The following is a description of a gene set: from publication Nakamura T, Fidler IJ, Coombes KR (PMID 17210693) To determine the influence of the microenvironment on changes in gene expression, we did microarray analysis on three variant lines of a human pancreatic cancer (FG, L3.3, and L3.6pl) with different metastatic potentials. The variant lines were grown in tissue culture in the subcutis (ectopic) or pancreas (orthotopic) of nude mice. Compared with tissue culture, the number of genes of which the expression was affected by the microenvironment was up-regulated in tumors growing in the subcutis and pancreas. In addition, highly metastatic L3.6pl cells growing in the pancreas expressed significantly higher levels of genes than did the L3.3 or FG variant cells. Growth of the variant lines in the subcutis did not yield similar results, indicating that the orthotopic microenvironment significantly influences gene expression in pancreatic cancer cells. These data suggest that investigations of the functional consequence of gene expression require accounting for experimental growth conditions. species: Homo sapiens Human Gene Set: NAKAMURA_METASTASIS_MODEL_UP Top genes up-regulated in orthotopic tumors from highly metastatic pancreatic cancer cells., and this is the list of marker genes: TOLLIP, DUSP3, NOB1, GRK5, KRT13, SLC16A3, PDE10A, HTRA2, PDK3, PADI3, TYRO3, PGK1, STX4 (NCBI Gene Id 6810), HS3ST1, HIRIP3, BLVRA, PABPC4L, TUBB2A, CMTM3, HPDL, COL17A1, C10orf95-AS1, MALL, FRMD8, NECTIN3-AS1, FOSL1, ADCY3, DUSP5, ACD, DPCD, DYNLL2, DDX24, MEPCE, FOLH1, TOR4A, LAPTM5, FKBP10, NTRK2, TUBB6, GJB3, AKAP13, LINC02114, HCLS1, GGA2, HOXB7